The following is a description of a gene set: Human Gene Set: chr4p15 species: Homo sapiens, and this is the list of marker genes: LINC02497, MIR573, C9orf78P2, LINC02473, RNU6-578P, SOD3, RNU6-573P, LINC02438, LINC02270, MTND3P5, PROM1, EEF1A1P21, ENSG00000283666, FGFBP2, LINC02360 (NCBI Gene Id 105374484), NCAPG, MTND2P31, ATP5MGP3, MTND4P9, SEPSECS, LINC02506, ENSG00000238694, LINC02364, MIR4275 (NCBI Gene Id 100422937), DCAF16, RPS3AP17, ECM1P2, LAP3, SLIT2, SEC63P2, RPL31P31, ENSG00000250092, PPARGC1A, ADGRA3, RN7SL101P, SMIM20, RAB28, ZCCHC4, STIM2, KCNIP4, CD38, MTND5P4, HNRNPA1P65, LINC01097, FGFBP1, TBC1D19, ENSG00000303533, BOD1L1, LINC02353, MIR572, C1QTNF7, HPRT1P1, ENSG00000306142, ENSG00000296976, MIR7978, MESTP3, ENSG00000200999, FAM184B, TAPT1-AS1, RNA5SP157, RPS7P6, ERVH-1, PI4K2B, ENSG00000249631, SNORA63 (NCBI Gene Id 6043), CCKAR, CPEB2-DT, FBXL5, MED28, HS3ST1, RNPS1P1, LINC02472, MTND4LP22, NACAP5, LGI2, HSP90AB2P, RPL32P12, C1QTNF7-AS1, RPS29P11, LDB2, TAPT1, RBPJ (NCBI Gene Id 51580), ZEB2P1, LINC01182, LINC02501, ENSG00000249453, FAM200B, DHX15, LINC01096, ENSG00000304023, RPL31P25, RN7SL16P, LINC02261, MTCYBP43, RNA5SP156, QDPR, LCORL, ENSG00000248837, PACRGL, LINC01085, RNU7-126P, RPL21P46, ANAPC4, RFPL4AP3, RN7SKP170, SNORA75B, CDC42P6, RNU6-420P, IGBP1P5, LINC02493, ENSG00000309702, SLIT2-IT1, SLIRPP2, SLC34A2, ENSG00000298600, LINC02357, BST1, STIM2-AS1, ENSG00000250954, PCDH7, RPS21P4, PIMREGP4, MED28-DT, ENSG00000302045, MAPRE1P2, NKX3-2 (NK3 homeobox 2), CLRN2, CCDC149, SEL1L3, MIR5091, LINC00504, GBA3, LINC02484, ENSG00000297225, KRT18P63, KCNIP4-IT1, CC2D2A, CPEB2, MTCO3P44, PFDN1P2, SEPSECS-AS1, MIR218-1, RPS27P13